The following is a description of a gene set: Human Gene Set: MODULE_430 Genes in the cancer module 430. species: Homo sapiens, and this is the list of marker genes: NCF1C, SNX17, SH2B2, DOCK2, RAC2, TTC7A, SYK, LSP1, SURF1, TTLL3, ARHGDIB, ISG20, NUMA1, SYVN1, GRK2 (G protein-coupled receptor kinase 2), MEN1, GCH1, PPP6R1, MOB3A, RPS9, TYK2 (NCBI Gene Id 7297), MAP4K1, ABTB1, SIPA1, CAPN10, CEP192, NBEAL2, CYFIP2, CORO1A, TAFAZZIN, RAB4B, TCIRG1 (T cell immune regulator 1, ATPase H+ transporting V0 subunit a3), DPH1, UCP1, FANCA, WDR76, TRAP1, ARHGEF1, CCND3, INPP5D, SPPL2B, PKN1, HDAC10, HDAC7, GMEB2, MAP4K2, BTBD2, NME3, FAM32A, ARPC2, HP1BP3, LIMD2, DECR1, SOCS7, MX2